The following is a description of a gene set: Any process that activates or increases the frequency, rate or extent of thyroid hormone generation. Mouse Gene Set: GOBP_POSITIVE_REGULATION_OF_THYROID_HORMONE_GENERATION species: Mus musculus, and this is the list of marker genes: Ctns, Pax8, Slco1c1, Gata3, Hpn